Given this list of marker genes ZFYVE19, E2F8, TXNIP, E2F7, ASPM, CHMP4C, BLM, MYC, GPR15LG, MIR145, INTU, VPS4A, AURKB (NCBI Gene Id 9212), TEX14, PTCH1, SUSD2, here is a description of the gene set: Human Gene Set: GOBP_NEGATIVE_REGULATION_OF_CELL_DIVISION studied in species Homo sapiens Any process that stops, prevents, or reduces the frequency, rate or extent of cell division.